Given this list of marker genes Tnfrsf11b, Ptgr1, Chd2, Ppp2ca, Med13, Golga7, Tomm20l, Rufy2, Opa1, Spry2, Zhx1, Sel1l3, Slc6a1, Ube3a, Atxn7l1, Lcp2, Slc4a7, Srsf11, Mplkip, Mafb, Mphosph9, Rprd1a, Tanc2, Rpe, Desi2, Eif1b, Kit, Cdh2, Ptpn13, Ikzf2, Lipk, Pls3, Abhd17b, Hnrnpr (heterogeneous nuclear ribonucleoprotein R), Sec62, Ubqln2, Rab40c, Runx2, Smad2, Chd1, Sema6d, Ppp1cb, Rfx7, Rab5a, Sp3, Aktip, Fhl1, Zc3h13, Commd10, Baz2b, Dennd4c, Adrb2, Cebpd, Slfn9, Zfp169, Yy2 (Yy2 transcription factor), Ghitm, Pak5, Cdk5r2, Scai, Vti1b, Hycc2, Fign, Chmp2b, Cdc73, Syne2, Grap2, Marchf6, Egr3, Denr, Rdh10, Nudt4, Arhgef7, Eif5a2, Kif2b (kinesin family member 2B), Rora, Smim14, Cnot8, Sox2, Serpinb7, Hdac9, Lats2 (large tumor suppressor 2), Reps2, Ythdf3, Bdnf, Rapgef2, 9930111J21Rik2, Trim2, Ppp4r1, Slit2, Bcl11b, Htr1a, Tgfbr1, Mkx, Ramacl, Slc40a1, Gca, Rbm12 (RNA binding motif protein 12), Csnk1g3, Etaa1, Mrps2, Mtm1, Slc25a40, Lipo1 (lipase, member O1), Pgap1, Slfn8, Edem3, Ebf2, Clcn3, Fubp1, Sp4, Trpm3, Actr6, Dhx15, Fam221a, Frem2, Smad6, Akr1c20, Plxna2, Steap2, Tctn1, Gcg, Itga8, Ppp1r3a, Slc25a30, Rad54b, Acyp2, Cadm2, Ankib1, Tle1, Hmcn1, Unc5d, Dock9, Rfpl4b, Tmem161b, Rab7, Icos, Dcaf10, Tpd52, Tob1, Phf11d, Ywhag (tyrosine 3-monooxygenase/tryptophan 5-monooxygenase activation protein, gamma polypeptide), Tet3, Pitpnb, AI597479, Utrn, Pax9, Scd2, Mon2, Zfp882, P2ry1, Ncl, Ube2q2, Lias, Bclaf3, Zfp36l2, Neurod1, Gm8978, Slc19a2, Hipk3, Atg5, Gjb1, Vps26a, here is a description of the gene set: species: Mus musculus Mouse Gene Set: MIR_6972_3P from publication Chen Y, Wang X (PMID 31504780) Genes predicted to be targets of miRBase v22 microRNA mmu_miR_6972_3p in miRDB v6.0 with MirTarget v4 prediction scores > 80 (high confidence targets).